Given this list of marker genes CPTP, MTTP, PLEKHA8, GLTPD2, PLEKHA8P1, CERT1, GLTP, here is a description of the gene set: species: Homo sapiens Human Gene Set: GOBP_CERAMIDE_1_PHOSPHATE_TRANSPORT The directed movement of a ceramide 1-phosphate into, out of or within a cell, or between cells, by means of some agent such as a transporter or pore.